Given this list of marker genes PTGER1, AKAP8, P2RY4, ACACA, GNRH1, PTGER2, PRKCE, PTGER4, SFRP1, GNG2 (NCBI Gene Id 54331), PRKAA1, AKT1, ADCY6, CCR7, GNB1, TGFBR3, GNAS, GNAI1, AANAT, SCN11A, PPP1R9B, TNFSF4, P2RY6, CCL21, PRKAA2, OXT, GNAQ, CCL19, here is a description of the gene set: species: Homo sapiens Human Gene Set: GOBP_RESPONSE_TO_PROSTAGLANDIN_E Any process that results in a change in state or activity of a cell or an organism (in terms of movement, secretion, enzyme production, gene expression, etc.) as a result of a prostagladin E stimulus.